Given this list of marker genes DPP10, P2RX3, ASIC2, DRD2, GRM3, ZACN, GRIK5, MT-ATP8, KCNJ13, CACNA1D, NPY2R, CHRNA6, KCNA10, CAV3, RYR3, TRPV4, TRPV5, SCNN1A, CACNA1F, AMIGO1, ADRB2, ATP5PD, OTOP2, CACNG6, CHRNA5, GRIN2A, CHRNE, WWP2, KCNH7, CACNA2D3, CACNA1B, KCNH6, OPRM1, CHRNA10, STX1A, LRRC26, PRKCB, OXSR1, ATP2B4, DRD4, PSEN1, CHRNA3, CHRNB2, HTR3B, KCNK15 (NCBI Gene Id 64181), CHRNA2, CHRNA4, TSPAN13, CHRNA7, KCNS3, KCNJ2, ATP5F1A, KCNIP1, OTOP3, CHRNA9, KCNA6, SCN11A, CACNG1, KCNIP2, KCNS1, SLC6A4, KCNAB2, SCN9A, SCN3A, CNGA2, ATP2A2, ORAI3, SCN4B, CACNB2, ASIC5, ITGAV, KCNN1, CABP4, PKD1L2, SCN7A, KCNJ6, TNNI3 (troponin I3, cardiac type), GRM2 (NCBI Gene Id 2912), UNC80, STK39, GRIK4, CALHM1, FGF13, NALF1, CACNB3, TMEM175, SCN10A, CACNA1H, ATP5ME, TRPC5, ATP5PF, TMEM63B, CACNA1E, KCNJ9, KCNT2, HCN4, CNGA3, SGK1, CALHM3, TMBIM4, KCNJ1, KCNV1 (NCBI Gene Id 27012), TMEM109, HVCN1, SCLT1, MT-ATP6, ATP5F1D, CACNB1, TRPA1, YWHAH (NCBI Gene Id 7533), KCNQ5 (NCBI Gene Id 56479), KCNN2, CHRNG, AKT1, SLC24A3, RASA1, KCNIP4, TPCN1, PKD2, CHP1, KCNJ14, PACSIN3, KCNA2, ATP5MF, ATP2A3, KCNIP3, SLC24A2, KCNH4, FXYD2, GRIN2D, ATP5MGL, NEDD4L, ATP6V0C, DPP6, CALM3, KCNK1, PKDREJ, ANK3, KCNJ5, CALHM4 (NCBI Gene Id 221301), CACHD1, STIM2, KCNB2, AQP1, PDE4D, CATSPER4, NALF2, MICU3, CACNG5, CALM1, MCOLN2, KCNK6, ATP5MG, GHITM, TMEM168, KCNJ12, TRPC6, C8orf44-SGK3, TMBIM6, LRRC55, KCNK13, GLRX, TMEM37, CHRNA1, SEC61A1, P2RX7, KCNB1, GRIN2B, CNGA1, TRPM3, TRPM8, CHRND, DLG1, KCNG4, KCNK3, GRINA, KCNG3, CACNA1C, CACNA2D1, PDE4B, CACNA2D4 (NCBI Gene Id 93589), P2RX2, SCN8A, GPD1L (NCBI Gene Id 23171), FLNA, KCNT1, FXYD6, TMEM38B, CNGB1, ITPR3, TRPC4, KCNH8, TRPC1, HPCAL4, GEM, CATSPER2, KCNMB1, KCNU1, STIM1, GRIN1, AGT, TMEM150C, GSTM2, ASIC1, KCNH3, ATP5F1E, PCSK9, KCNMB2, CCDC51, NOX5, TRPV6, ANO9, KCNJ16, MCUB, TMEM38A, KCNA1, CACNG7, CACNG2, KCNQ4, ANK2, PIEZO1, PRKG1, AKAP9, KCNK2, KCNQ2, KCNJ3, REM1, KCNA5 (NCBI Gene Id 3741), CCT8L2, KCNA3, RANGRF, TRPC4AP, HTR3E, HTR3D, CACNG4, KCNH1, SGK3, STIMATE, ATP5PO, NALCN, FHL1, RYR2, ANO6, SCNN1B, FXYD4, TMBIM1, STING1, GRIA3, KCNJ8, TRPM5, KCNE4, TMCO1 (transmembrane and coiled-coil domains 1), ARPP19, GRIA1, TRPM2, TRPV2, KCNMB4, CALHM6, OTOP1, CACNA2D2, KCNK16, ATP5PB, TRPV3, HTR3A, CACNA1A, SNTA1, KCND1, TRPC7, FXYD3, SLC24A5, PKP2 (NCBI Gene Id 93271), SNAP25, ABCC9, TRPM7, CAV1, FKBP1B, SCN5A, GRIN3B, CATSPER3, HTR3C (5-hydroxytryptamine receptor 3C), TRPC3, GPM6A, LRRC52, ABCC8, FXYD1, SLC4A11, SCN2A, SGK2, KCNAB1, COMMD1, FXYD5, KCNK4, ASIC4, CYBB, KCNQ1, KCNK10, CATSPER1, CAMK2D, CALM2, KCNF1, TMC2, GRIK1, KCNN3, NRXN1, HCN3, FAIM2, ENSA, PKD1L1, TMEM63A (transmembrane protein 63A), SCN1B, KCNAB3, GRIK2, NEDD4, SCN4A, SHROOM2, CACNG8, GRIK3, PANX1, KCNJ18, KCND3, KCNC2, KCNJ15, TMC1, P2RX4, CACNA1S, CHRNB4, PTPN3, NPY, RASA3, LRRC38, KCNK9, CHRFAM7A, BEST2, REM2, MCOLN3, ORAI1, CUL5, GRIN3A, SLC30A1, NRXN2, KCNE5, GPLD1, YWHAE, HCN2, CACNG3, KCNC4 (potassium voltage-gated channel subfamily C member 4), KCNJ11, KCNK7, FKBP1A, ITPR2, TMEM63C, RRAD, ATP5F1EP2, SCNN1D, CHRNB1, P2RX6, PHPT1, KCNC1, KCNG1, FGF11, TMEM87A, SLC24A1, ASIC3, SCN1A, SCNN1G, TRPM1, KCNA4, ITPR1, KCNG2, TRPM6, KCNJ4, FGF12, KCNJ10, KCNK17, KCNMA1, MICU2, ATP5F1B, CACNA1I, TMPRSS3, TRPM4, SRI, KCNK5, KCNE3, KCNS2, GRIA2, KCNC3, SLC24A4, NCS1, KCND2, TRPV1, CABP5, PKD1L3, KCNE1, KCNN4 (NCBI Gene Id 3783), CABP1, KCNK18, HCN1, ATP5F1C, KCNV2, FXYD7, ORAI2, GRIN2C, TSPOAP1, KCNK12, SLC5A3, PKD1, PKD2L1, TPCN2, PIEZO2, P2RX1, P2RX5, KCNH2, CACNB4, KCNE2, ATP5MC1, MICU1, BNIP1, MCU, PANX3, AMBP, RSC1A1, CNGB3, FXYD6P3, CALHM2, NOS1, KCNH5, CNGA4, ANO10, CRISP1, FGF14, ANO1, SUMO1, PKD2L2, KCNA7, SCN2B, CABP2, CALHM5, KCNMB3, CACNA1G, SCN3B, RYR1, CHRNB3, MCOLN1, KCNQ3, here is a description of the gene set: Human Gene Set: GOMF_MONOATOMIC_CATION_CHANNEL_ACTIVITY Enables the energy-independent facilitated diffusion of a monoatomic cation through a transmembrane aqueous pore or channel. species: Homo sapiens